Given this list of marker genes SP1, MTSS1, FZD5, CCND2, SLC7A8, SIRPA, GRM1, MYO1B, ADSS2, IDH2, DLX5, NRG2, RPP14, FGF9, CAMTA1, HADH, INPP5A, KIAA1143, SLC12A9, NEMP1, ARFGAP2, PIK3C2A, FOXK2, ZFPM2, CEP170B, CEP43, DNAJC3, OGFOD2, NXN, EIF4EBP2, RNF152, PDE6C, ARHGEF12, NEUROD4, KLF6, FOXO1, SLC26A7, ANKRD40 (NCBI Gene Id 91369), JHY, ARMC7, IL17RD, VKORC1L1, NFYB, FBXL5, MMD2, UBTD2, COMMD7 (COMM domain containing 7), ZNF695, DZIP1, AMMECR1L, TMEM214, UGT8, SERF2, STX17, L3MBTL3, HDAC7, HS3ST5 (NCBI Gene Id 222537), OVOL1, SOCS7, GNAI3, LDLRAP1, IKZF2, MAP3K20 (NCBI Gene Id 51784), TLCD3A, RGPD2, GRIK4, EGR1, KLHL24, OTUD4, MYO18A, NCDN, GLRX3, XIAP, FAF2, PDE3A, DCUN1D2, ZNF496, CDCA7L, CMTM4, SPSB1, KRT74, RHOG, DPP8, ST6GALNAC4, DOP1A, OVOL2, DUSP18, CTDSP1, TOR3A, ZDHHC17, FBXO41, FLOT2, PLK3, RPP30, MSN, STK36, ARK2C, JPT2, USP49, OSBPL11, CCND1, KIF13A, B3GALT1, RNF19A, ARHGAP21, FMC1-LUC7L2, RALB, SEC24D, STK26, PSD3, OGT, PAM, CELSR3, TET1, CSMD1, TRPM3, ATF7IP, PTPDC1, ROBO2, COL11A1, DAZAP2, LUC7L2, SLC25A44, SRGAP3, ANKRD44, NDST1, RIMS4, SRSF10, SPOCK3, RPS6KA6, GALNT13, CHIC2, FRMD5, PSEN2, PLEKHF2, EPB41L4B, LNX2, FUT8, CCDC190, MAP4K5, MYO5B, FKBP9, TET3, HCN1, AZIN1, CARHSP1, MBNL3, OTUD7A, ELMO2, RUFY2, SERTAD4, CAV1, TTYH3, WIPF1, HEATR1, HP1BP3, TMEM117 (transmembrane protein 117), TWSG1, CYGB, PAFAH1B1, LRCH2, SNX1, C12orf60, PCDH15, here is a description of the gene set: studied in species Homo sapiens Genes predicted to be targets of miRBase v22 microRNA hsa-miR-593-5p in miRDB v6.0 with MirTarget v4 prediction scores > 80 (high confidence targets). Human Gene Set: MIR593_5P from publication Chen Y, Wang X (PMID 31504780)